Given this list of marker genes STEAP2, CYB561A3, STEAP3, STEAP1, FXN, FTH1, CYBRD1, MTRR, HEPHL1, STEAP4, CYB561D1, HEPH, FRRS1, MMACHC, FTMT, CP (ceruloplasmin), CYB561D2, here is a description of the gene set: species: Homo sapiens Human Gene Set: GOMF_OXIDOREDUCTASE_ACTIVITY_ACTING_ON_METAL_IONS Catalysis of an oxidation-reduction in which the oxidation state of metal ion is altered.